The following is a description of a gene set: Human Gene Set: HP_NEONATAL_DEATH Neonatal death Death within the first 28 days of life. studied in species Homo sapiens, and this is the list of marker genes: RMND1, MBTPS2, PAICS, TMEM70, SLC25A4, PKHD1, FOXF1, NFU1, MOCS2, JAM3, EDNRB, HADHB, GLI3, LBR, CTSD, GATC, PLS3, ZMPSTE24, CRLS1, ZIC3, BCS1L (BCS1 homolog, ubiquinol-cytochrome c reductase complex chaperone), PET100, PHGDH, FGFR3, SDHD, FGG, SUCLG1, GBA1, FLNB, THSD1, TARS2, MDFIC, ATP5F1A, DONSON, ETFA, FGA, ABCA3, FANCB, PEX10, SCN4A, HSPG2, PIP5K1C, PLEC, CEP55, ATP1A2, NDUFAF4, ABCA12, ETFDH (NCBI Gene Id 2110), LMOD1, DSP, QRSL1, GAD1, GLUL, NEB, AARS2, RBM10, NDUFS6, SFTPB, IL6ST, NPHP3, CDK5, SLC25A24 (solute carrier family 25 member 24), RARB, HTRA2, MRPS16, PEX14, FAM20C, CNOT1, RAD51C, GET3, AP1S1, ACTA1, IFT56, FGB, PPFIBP1, ATAD3A, GPHN, GLE1, NUP88, EFEMP2, LMOD3, CNTNAP1 (contactin associated protein 1), NDUFB10, ADCY6, LMOD2, STRA6, WT1, ITGA6, TBXT, ALG8, INTU, ETFB, NDUFB11